Given this list of marker genes H2-M10.3, H2-Q10, H2-M10.5, H2-Q2, H2-M10.4, H2-M10.1 (NCBI Gene Id 14985), H2-M10.2, H2-M2, H2-Q1, H2-T10, H2-D1, H2-M11, Tap2, Tapbp, H2-T22 (NCBI Gene Id 15051), H2-Q7, H2-M10.6, H2-Q4, Tap1, H2-M9, H2-Q6, H2-M5, H2-T3, H2-K1, H2-M1, here is a description of the gene set: Binding to TAP protein, transporter associated with antigen processing protein. TAP protein is a heterodimeric peptide transporter consisting of the subunits TAP1 and TAP2. Mouse Gene Set: GOMF_TAP_BINDING studied in species Mus musculus